The following is a description of a gene set: Human Gene Set: QUEREC_PBMC_YF_17D_VACCINE_AGE_18_45YO_3DY_UP studied in species Homo sapiens from publication Querec TD, Akondy RS, Lee EK, Cao W, Nakaya HI, Teuwen D, Pirani A, Gernert K, Deng J, Marzolf B, Kennedy K, Wu H, Bennouna S, Oluoch H, Miller J, Vencio RZ, Mulligan M, Aderem A, Ahmed R, Pulendran B (PMID 19029902) A major challenge in vaccinology is to prospectively determine vaccine efficacy. Here we have used a systems biology approach to identify early gene 'signatures' that predicted immune responses in humans vaccinated with yellow fever vaccine YF-17D. Vaccination induced genes that regulate virus innate sensing and type I interferon production. Computational analyses identified a gene signature, including complement protein C1qB and eukaryotic translation initiation factor 2 alpha kinase 4-an orchestrator of the integrated stress response-that correlated with and predicted YF-17D CD8(+) T cell responses with up to 90% accuracy in an independent, blinded trial. A distinct signature, including B cell growth factor TNFRS17, predicted the neutralizing antibody response with up to 100% accuracy. These data highlight the utility of systems biology approaches in predicting vaccine efficacy. Genes up-regulated in peripheral blood mononuclear cell 3d vs 0d in adults (18-45) after exposure to YF-17D vaccine, time point 3D, and this is the list of marker genes: IFIT2, OAS1 (2'-5'-oligoadenylate synthetase 1), MX2, SERPING1, SAMD9L, IFIH1, IFIT3, DDX60L, PARP12, RIGI, MYOF, IRF7, DDX60, OAS3, PNPT1, IFI44L, OAS2, STAT1, PLSCR1, LGALS3BP, EIF2AK2, TMEM255A, RSAD2, RGL1, IL10, NEXN, DHX58, TRIM5, IFI27, RASA2, SAMD9, PARP9, TRIM22, ISG15, XAF1, IFIT1, LAMP3, MX1, IFI44, HERC5, OASL, IFI6, TLR7, CXCL10, C3AR1, CD38